Given this list of marker genes PLAAT3, UFD1, LGALS3, SDC4, CDK18, FDFT1, TXK, SOAT1, NDUFS4, RUNX3, NRG2, PCMT1, GNA15, STAT4, PLIN2, COL9A3, CDC16, GLIPR1, KDM6A, here is a description of the gene set: species: Homo sapiens from publication Visala Rao D, Boyle GM, Parsons PG, Watson K, Jones GL (PMID 12618007) Genes down-regulated in peripheral lymphocytes from old individuals compared to those from young donors. Human Gene Set: VISALA_AGING_LYMPHOCYTE_DN Ageing results in a progressive, intrinsic and generalised imbalance of the control of regulatory systems. A key manifestation of this complex biological process includes the attenuation of the universal stress response. Here we provide the first global assessment of the ageing process as it affects the heat shock response, utilising human peripheral lymphocytes and cDNA microarray analysis. The genomic approach employed in our preliminary study was supplemented with a proteomic approach. In addition, the current study correlates the in vivo total antioxidant status with the age-related differential gene expression as well as the translational kinetics of heat shock proteins (hsps). Most of the genes encoding stress response proteins on the 4224 element microarray used in this study were significantly elevated after heat shock treatment of lymphocytes obtained from both young and old individuals albeit to a greater extent in the young. Cell signaling and signal transduction genes as well as some oxidoreductases showed varied response. Results from translational kinetics of induction of major hsps, from 0 to 24 h recovery period were broadly consistent with the differential expression of HSC 70 and HSP genes. Total antioxidant levels in plasma from old individuals were found to be significantly lower by comparison with young, in agreement with the widely acknowledged role of oxidant homeostasis in the ageing process.